Given this list of marker genes Strap, Fmr1, Smn1, Ddx20, Gemin8, Gemin4, Gemin6, Gemin5, Gemin2, Gemin6-ps, Gemin7, here is a description of the gene set: Mouse Gene Set: GOCC_SMN_COMPLEX species: Mus musculus A protein complex that contains the survival motor neuron (SMN) protein and at least eight additional integral components, including the Gemin2-8 and Unrip proteins; the complex is found in the cytoplasm and in nuclear Gems, and is involved in spliceosomal snRNP assembly in the cytoplasm and in pre-mRNA splicing in the nucleus.